The following is a description of a gene set: species: Mus musculus Mouse Gene Set: GOCC_CHROMOSOMAL_REGION Any subdivision of a chromosome along its length., and this is the list of marker genes: Cenpt, Acd, Smarcb1, Spo11, Mis18bp1, Spout1, Cenph, Alyref, Cdc20, Fen1, Ten1, Trappc12, Incenp, Uhrf2, Mis12, Stag2, Bod1, Psen1, H2ac8, Sgo2b, Telo2, Dnmt1, Ercc4, Dync1li2 (NCBI Gene Id 234663), Pbrm1, Pmf1, H2bc21, Zfp330, Nek2, Dmc1, Chmp1a, Sec13, Dclre1b, Nup160, Top2a, Nup133, H4c17, Pold1, Dhx36, Rbbp4, Upf1, Champ1, Kif18a, Pot1a, Phf6, Baz1a, Mki67, Polr2b, Ckap5, Mta2, Mis18a, Snai1, Cdk2, Hells (NCBI Gene Id 77871), Smc4, Rad51, Trp53bp1, Cenpc1, Cenpx, H4c12, Rec8, Kmt5b, Rad17, Mtbp, Blm, Hsf1 (heat shock factor 1), Pinx1, Luzp1, Smc3, Cenpp, H2ac6, Ppp2r1a, Alyreffm10, Seh1l, Cenps, Septin2, Pot1b, Chmp2a, Sycp3, Alyreffm7, Smarcc1, Cenpa, BC005624, Dctn6, Ncapd2, Brca2, Lrif1, Chd4, Bub1, Birc5, Thoc7, H2ac7, Csnk1a1, Dync1li1, Alyreffm11, Psen2, Ppp2r5c, Dna2, Chrac1, Smc5, Ccnb1-ps, Daxx (NCBI Gene Id 13163), Cebpb, Ctc1, Chmp4c, Tfip11, Smchd1, H2al2a, Flywch1, Crebbp, Wdhd1, Kdm1a, H2al1a, Tinf2, Ndc80, Smc6, Spc24, H2ac22, Phf2, Rtel1, Dctn1, Ska2, Zfp618, Alyreffm8, Terb1, Cdt1, Tex14, Cenpw, Fbxw11 (NCBI Gene Id 72380), Kif2c, Alyreffm4, Gtf2b, Cenpf, Ezh1, Anapc16, Pafah1b1, Ppp1r10, Meaf6, Nabp1, Mad1l1, Ska1, Ppp1r12a, Nuf2, H2ac4, Mad2l1, Terf2ip, Stn1, Ppp1ca, Hat1, Spag5, H4c14, Cenpe, Ska3, Actl6a, Men1, Ngdn, H4c18, Ccnb1, Prpf4b, Itgb3bp, Alyreffm5, Rassf2 (Ras association (RalGDS/AF-6) domain family member 2), Sun2, Spdl1, Ppp1cc, Cbx3, Ncapg, Sycp2l, Septin7, Cenpv, Plk2, H2ac13, H4c4, Suv39h2, Thoc6, Atf7, Cenpo, H4c9, Zscan4d, Thoc2, Plk3, Clasp2, Cenpi, Hjurp, Smc1a, Fmr1, Alyref2, Eid3, Cenpb (centromere protein B), Ctcf, Actb, Dapk3 (death-associated protein kinase 3), H4c16, Alyreffm6, Terb2, Chek2, Kntc1, Firrm, Sirt6, Kif2b, Chmp3, Kdm4b, Sycp2, Majin, Smarce1, H3f3b, Ercc1, Sun1 (NCBI Gene Id 77053), Orc1, Atm, Rangap1, Actl6b, Rad51ap1, Smg6, Smarca5, Fbxo28, Xrcc1, Terf2, Tox4, Aurkc, Zfp276 (NCBI Gene Id 57247), Spc25, Esco2, Chmp1b2, Ss18l1, Spdya, Tnks2, Cenpu, Nsmce3, Bub3, Dctn5, Zbtb10, Nup98, Ncapd3, Sgo2a, Thoc2l, Ndel1, Kdm4c, Zbtb48, Recql4, Zfp207, Gpatch11, Tep1, Cenpm, Rad50, Zwint, Wdr82, Rbbp7, Nsmce2, Smarcd1, Uvrag (UV radiation resistance associated gene), Septin6, Baz1b, Ahctf1, Kat8, Nde1, Kdm4d, Kmt5c, Kash5, Kansl1, Gar1, Sgo1, Zwilch (zwilch kinetochore protein), Knstrn, Terf1 (telomeric repeat binding factor 1), Rcc2, Cenpk, Chek1, Ppp2ca, Smarca4 (NCBI Gene Id 20586), Sugt1, H3f3a, Dsn1, Aurkb, H4c11, Wrnip1, Zw10, Kat5, Chmp6 (NCBI Gene Id 69715), Nsl1 (NSL1, MIS12 kinetochore complex component), Knl1, Chmp2b, Nup37, Zfp827, Cfdp1, Plk5, Mtcl1, Pml, Slx4, Orc2, Cenpl, Macroh2a1, Alyreffm9, Xrcc5, Ppp2r5a, H4c3, Bub1b, Cbx1 (chromobox 1), Chmp4b, Chmp7, Rif1, Tpr, Rad21, Rnf8, Chmp5, Hnrnpu (heterogeneous nuclear ribonucleoprotein U), Ppp1ccb, Xpo1, Nup85, Plk1 (polo like kinase 1), Smarcc2, Dscc1, H4c1, Zscan4c, Meikin, Wrap53, Nup43, Nabp2, Kdm4a, Smc1b, Suv39h1, Cenpn, Cenpq, Hnrnpa2b1, Arhgap33os, Apc, Rpa2 (NCBI Gene Id 99984), Hmbox1, H4c2, Pole3, Sycp1, H4c6, Dynll1, Nsmce1, Smarcd2, Phf10, Thoc5, Nlrp2, Alyreffm3, Cbx5, Ercc6l, Gatad2b, Oip5, Nudcd2, Dctn4, Brd7, Ppp2cb, Dync1i1, Setx, Thoc3, Tert (telomerase reverse transcriptase), Atrx, H2ax, Cdca8, Pif1, Dctn3, Rad51d, Ppp1cb, Sin3a, Dnmt3b, Nup107, Alyreffm1, Stag3, Clasp1, Chmp1b, Ikzf1, Ezh2, Dctn2 (NCBI Gene Id 97666), H4c8, Nbn, Tnks, Kat2b, Xrcc4, Pkhd1, Ttk, H2bw2, Thoc1, H2ac23, Kat7, Arid2, Lrwd1, Dnmt3a, Orc4, Zscan4f, Hdac2, Dynlt3, H2ac24, Mre11a, Wrn, Aurka